Given this list of marker genes FPR1, GNAT3 (NCBI Gene Id 399515), GIPR, ADRB3, RGS11, HTR1D, LPAR3, AGTR1, EDNRA, PDE8B, ARHGEF39, OBSCN, PTH2 (NCBI Gene Id 113091), OPN1SW, CALM1, HCAR1, CALCB, CRHR1, PLPPR5, PRKAR2A, TAS2R41, RGR, CHRM4, ADCY1, RXFP4, PPP3CB, OPRL1, GPR31, ECE1, ARHGEF37, ADCY9, RGS20, MCHR1, GNAI2, CD55, DRD5, VAV2, S1PR3, HCAR3 (hydroxycarboxylic acid receptor 3), IHH, PDE2A, NPSR1, CCR5, TAS1R3, PLEKHG5, S1PR2, GNG13, F2RL2, VAV1, SMO, ACKR2, PENK (proenkephalin), PDE4B, VIPR1, PRKCG (NCBI Gene Id 57013), NMBR, GNAZ, PRKAR1A, KEL, ADCY2, NMUR2, TAS2R7, CRHR2, MC2R, PRKACG, CDK5, PAK1, GNA14, SUCNR1, ARHGEF38, TACR2 (NCBI Gene Id 6865), WNT8A, IAPP, ADCY8, ADRA2A, GNRH1, NPW, RGS10, P2RY12, INSL5, PPP2R1A, POMC, XCL2, RXFP2, NPS, PROKR2, CX3CL1, GABBR2, TBXA2R, GNG2, FZD7, MLNR, TAS2R16, NPBWR1, HRH1, TAS2R1 (taste 2 receptor member 1), WNT3, GRK5, DAGLA, PROK2, PRKX, PLCB4, PPP3R1, RGSL1, DGKZ, LPAR6, RGS4, TAC1, GNAI3, PDE4A, PIK3CA, PLPPR1, INSL3, ADGRE2, PPP1CA, KISS1, NBEA, NTSR2, PRKCH, GNRH2, ARHGEF1, GRK6, DGKI, ADCY3, S1PR4, CCL28, GLP1R, GAST, CCL3, CXCL8, GPHB5, SRC, GNAL, APLN (NCBI Gene Id 8862), FGD1, GRM1, CCL5, PPP2CA, GPER1, HTR1E, LPAR5 (lysophosphatidic acid receptor 5), DAGLB, FGD2, ARHGEF35, CHRM3, HTR6, MAPK1, RGS13, GRM2 (glutamate metabotropic receptor 2), GPR39, GNG7, CCRL2, GCGR, GNA13, APLNR, HRH3, SCTR, PLPPR3, GALR2, CAMK2A, CXCL3, FZD1, PLCB2, HCRTR2, CHRM1, CCKBR, MT-RNR2, CCL27, TRHR, ARHGEF4, PLXNB1, WNT10B (NCBI Gene Id 82499), HTR2C, ARHGEF40, TAS2R14, PTGER1, P2RY14, ARHGEF25, ITPR1, FZD9, GHRH, EDN1, EDN2 (NCBI Gene Id 1907), RGS3, OXT, CXCL11, OPRM1, AKAP13, GPR32, PSAP, PIK3R1, MAPK3, RGS8, CCL17, UCN2, GNRHR, ACKR3, PDE4D, GPR18, CCL19, CCL1, PPY, CXCR1, GRM6, TAAR9, NPY, TAS2R60, ABHD6, CORT, LPAR1, CNR2, DGKD, WNT9B (NCBI Gene Id 7484), GPR150 (G protein-coupled receptor 150), C5, TAS2R3, CAMKK2, FZD5, NPY1R, VAV3, BRS3 (NCBI Gene Id 680), TAS2R50, RAMP1 (NCBI Gene Id 10267), CYSLTR2, CCR8, PTAFR, GHSR, PTH (parathyroid hormone), HTR1B, GPR25, ADRA1B, EDNRB, ADORA1, FZD8 (frizzled class receptor 8), CXCL1 (NCBI Gene Id 2919), NPB, CNR1, CDC42, PDE8A, HCRT, MGLL, TAS2R30, ITPR3, ARRB1 (NCBI Gene Id 408), TAS2R4, GNB2, P2RY4, WNT9A, HTR5A, PYY, PLPPR4, PDE4C, KPNA2, ARHGEF9, TACR3, QRFP, CHRM5, C5AR1, FGD3, RASGRP1, WNT10A, RGS9, NTS (NCBI Gene Id 96646), PTGER3, ARHGEF5, PTCH2, TAAR5 (trace amine associated receptor 5), SST, HCRTR1, RAMP2, OXGR1, GNAQ, LPAR2, DHH, GPSM3, CXCL13, AKT2, TRPC6, GNGT1, ARHGEF19, RGS2, TIAM1, CXCL5, PDPK1, CAMK2G (NCBI Gene Id 818), PIK3R6, CCR9, CCR6, TSHR, GRM5, UCN3, LPAR4, XK, VIP, P2RY2, PDE1A, GNG11, ARHGEF12, GRM8, CAMK4, GAL, GPHA2, ACKR4, PPP2R1B, NMS, AVPR1B, GPR37, RXFP3, CXCR6, SAA1, OPRK1, ARHGEF11, DGKE, GPR17, CCL11, MRGPRD, DRD1, GHRHR, C5AR2, ITSN1, SSTR2, PTH2R, VIPR2, NMUR1, PTHLH, CALCA, NPFF, CMKLR1, NPFFR1, TAS1R1, GPR35, HBEGF, GPR4, RGS14, GPR83, MCF2L, CCL13, GALR1, PNOC, C3AR1, NPY5R, RXFP1, ITGB1, GPR45, CREB1, FSHR, LTB4R, MC5R, RASGRF2, RGS12, CYSLTR1, MAPK7, PLCB3, RLN3, GNRHR2, GNAI1, RGS22, CXCR5, GRP (gastrin releasing peptide), NTSR1, PROK1, GPBAR1, TAS2R5, FSHB, ADCYAP1R1, GPSM2, DGKK, ABR, RRH (NCBI Gene Id 10692), GNAT2, AGT, AKT1, AVPR1A, GNG3, MC4R, DRD2, ARRB2, OPN1MW, KISS1R, PRKAR2B, CXCL12, ITPR2, ADORA3, FPR3, MMP3, TAS2R39, WNT8B, SSTR3 (somatostatin receptor 3), F2RL1, ARHGEF17, CCL20, LTB4R2, CXCR3, TAAR8, GRK2, RGS6, FFAR1, TAS2R38, GABBR1, PPP2CB, UCN, ARHGEF18, TAS2R42, KRAS, ANXA1, RHOC, NPY2R, GRM4, SSTR5, GNAS, CALCR, TRIO, CCL4, P2RY10, TAS2R31, RPS6KA1, PCP2, NET1, WNT16, OPN5, F2, OPN4, GPR68, TAS2R9, SCT, OXTR, RPS6KA2, ADM2, DGKQ, EDN3, CXCL10, PRKAR1B, AVPR2, CXCL6, FZD2, RGS1, XCL1, ADCY4, GHRL, GPR183, NMB, PIK3R5, C3, HRH2, FZD6, ADM, CXCL16, TAS2R8, MTNR1A, MC1R, CAMK2B, GPR143, ROCK2, KNG1 (NCBI Gene Id 589), GNG12, MLN, S1PR1, PRKCQ, ECE2 (endothelin converting enzyme 2), GPR65, NGEF, TAS2R10, CCL4L1, GPR27, PRKCB, ROCK1, OPRD1, PLCB1, TAAR1, CCK, NPBWR2, GPR20, GLP2R, TRPC3, GNA12, GRB2, RAMP3, RASGRP2, RPS6KA3 (ribosomal protein S6 kinase A3), GNB3, RGS16, AHCYL1, PDYN, PIK3CG, CCL22, LHCGR, PLPPR2, PTGER4, HRH4, SOS1, AGTR2, TAAR6, RHOA, CCKAR, PLA2G4A, PLEKHG2, GPR176, SOS2, CXCR4 (NCBI Gene Id 93405), F2RL3, TAS2R40, ADORA2A, SSTR1, GCG, XCR1, PPP1R1B, ARHGEF3, ADGRE3, CAMK2D (NCBI Gene Id 817), PDE1B, ADCY7, PDE7B, DGKB, PPP3CC, PRKCD, PTGIR, GNAT1, GPR37L1, GRM7, PRLHR, FGD4, FZD3, CAMKK1, PPBP, OXER1, ADRA2C, ADGRE5, TAS2R46, P2RY13, HTR1F, TAS1R2, SHH, GNG4, TAS2R43, WNT7A, GIP, ARHGEF7, RGS21, CCL21, BTK, GNB5, DGKA, ADCY5, ADRA1A, P2RY1, UTS2, CRHBP, HTR2B, ARHGEF6, CXCL9, F2R, GNA15, CCL23, RGS5, P2RY11, GRM3 (NCBI Gene Id 2913), GPRC6A, TAS2R45, CCL3L1, DRD3, ADRB2, ARHGEF10L, WNT1, PRKCA, CCR10, MAS1, PTGDR2, RHOB, CCL25, CCR3, GRK3, TAC3, MCHR2, ACKR1 (atypical chemokine receptor 1 (Duffy blood group)), WNT4, RHO, RGS19, PTGFR, KALRN, PMCH, CCL7, GNG8, WNT5A, HRAS, CALCRL (NCBI Gene Id 10203), ARHGEF26, CCR1, EGFR, PF4, FFAR3, WNT11, CRH, PDE7A, LHB, ARHGEF16, FZD4, ADCYAP1, UTS2R, TIAM2 (NCBI Gene Id 340133), PRKACB, S1PR5, MC3R, PTGER2, PDE1C, MCF2, PDE11A, BDKRB1, ADRB1, GNB4, PDE10A, GPR15, WNT2, BDKRB2, PTGDR, NLN, ITGA5, WNT3A, HTR1A, FFAR2, NMU (NCBI Gene Id 10874), RGS17, AKT3, ADRA2B, ABHD12, PIK3R2, PRKACA, HCAR2, PPP2R5D, GNGT2, PDE3A, TRH, RLN2, OPN1LW, MTNR1B, GNG5 (G protein subunit gamma 5), CCL2, DGKH, CCR4, RGS7, HEBP1, PTH1R, TAAR2, QRFPR, APP, WNT7B, ARHGEF10, TAS2R13, FZD10, ECT2, CCL16, SSTR4, GPR84, ADRA1D, PDE3B, GRPR, FPR2, ADGRE1, WNT2B, PIK3R3, CX3CR1, TAAR3P, TAS2R20, SHC1 (SHC adaptor protein 1), FFAR4, AVP, GNA11, TACR1, FN1, TRPC7, DGKG, WNT6, PREX1 (phosphatidylinositol-3,4,5-trisphosphate dependent Rac exchange factor 1), GALR3, NRAS, NPY4R, PPP3CA, HTR7, TAS2R19, ARHGEF15, PROKR1, CHRM2, HTR2A, ARHGEF2, P2RY6, GPR132, CGA, CXCL2, TSHB, CASR, PRKCE, CXCR2, ADCY6, GPR55, CCR2, ARHGEF33, RGS18, PTCH1, HTR4, GPSM1, PRLH, ADORA2B, CCR7, NPFFR2, OPN3, DRD4, UTS2B, GNG10, GNB1, here is a description of the gene set: Reactome Pathway: Signaling by GPCR part of: Signal Transduction species: Homo sapiens G protein-coupled receptors (GPCRs; 7TM receptors; seven transmembrane domain receptors; heptahelical receptors; G protein-linked receptors) are the largest family of transmembrane receptors in humans, accounting for more than 1% of the protein-coding capacity of the human genome. All known GPCRs share a common architecture of seven membrane-spanning helices connected by intra- and extracellular loops. The extracellular loops contain two highly-conserved cysteine residues that form disulphide bonds to stabilize the structure of the receptor. They recognize diverse messengers such as light, odorants, small molecules, hormones and neurotransmitters. Most GPCRs act as guanine nucleotide exchange factors; activated by ligand binding, they promote GDP-GTP exchange on associated heterotrimeric guanine nucleotide-binding (G) proteins. There are two models for GPCR-G Protein interactions: 1) ligand-GPCR binding first, then binding to G Proteins; 2) "Pre-coupling" of GPCRs and G Proteins before ligand binding (review Oldham WM and Hamm HE, 2008). These in turn activate effector enzymes or ion channels. GPCRs are involved in a range of physiological roles which include the visual sense, smell, behavioural regulation, functions of the autonomic nervous system and regulation of the immune system and inflammation.<br>GPCRs are divided into classes based on sequence homology and functional similarity. The main mammalian classes, in order of size, are the Rhodopsin-like family A, the Secretin receptor family B, and the Metabotropic glutamate/pheromone receptor family C.